Given this list of marker genes SIGIRR, MAP2K5, IL10, MUL1, MIR766, SIRPA, MIR214, ELANE, ERBIN, GSTP1, APOD, MEFV, KLF4, MIR140, OAS1, ARG2, MIR26B, F2RL1, MIR146A, TICAM2, EPHA2, SOCS5, MIR106A, C1QTNF3, MIR34A, LGALS9, NR1H4, OAS3, IL6, MIR590, LILRB4, MIR17, here is a description of the gene set: Human Gene Set: GOBP_NEGATIVE_REGULATION_OF_CHEMOKINE_PRODUCTION studied in species Homo sapiens Any process that stops, prevents, or reduces the frequency, rate, or extent of chemokine production.